Given this list of marker genes Kctd2, Klhl36, Kctd9, Klhl21, Dcun1d4, Kctd17, Ddb1, Asb2, Dcun1d1, Klhl13, Gmcl1, Anapc11, Skp1, Rbx1-ps, Klhl9, Dcun1d2, Klhl3, Tes3-ps, Dcun1d3, Prkn, Ccdc22, Btbd1, Rnf7l, Kctd5, Kctd6, Kctd21, Rbx1 (NCBI Gene Id 80401), Rnf7, Dcun1d5, here is a description of the gene set: Mouse Gene Set: GOMF_CULLIN_FAMILY_PROTEIN_BINDING studied in species Mus musculus Binding to a member of the cullin family, hydrophobic proteins that act as scaffolds for ubiquitin ligases (E3).